The following is a description of a gene set: species: Homo sapiens Human Gene Set: HP_PROMINENT_SUPRAORBITAL_RIDGES Prominent supraorbital ridges Greater than average forward and/or lateral protrusion of the supraorbital portion of the frontal bones., and this is the list of marker genes: WDR26 (WD repeat domain 26), ZSWIM6, GPR101, AP1G1, CAVIN1 (caveolae associated protein 1), PAK3, ARX, ABCC9, PHF8, KCNJ8, FHL1, RBMX (NCBI Gene Id 8258), CHD8, PITX2, FLNA, PHF6, PTH1R, ERCC4, TAF1, AGPAT2, GRIA3, FBXO31, FGFR1, COL11A2, IDS, CTCF, OPHN1, CAV1, EDA, FREM1, CRELD1, BSCL2, FBXL4, SUZ12, PSMC3, ANTXR1, RPS6KA3, PDGFRB (platelet derived growth factor receptor beta), SP7, HDAC8, LMBRD2, PIK3R1, PRR12, PPARG, MAP2K2, JARID2, FOS, TOE1, POLR3A, SEC23A, MAP3K7, SOST, LBR, LAS1L, SHANK3, AIP, UBE2A